Given this list of marker genes C1QL1, CAPS, DAO, MAPK1, SPATA2L, LRMDA, GABBR1, C3AR1, B4GALT1, CTAGE9, CDKN1C, AZGP1, EPHB6, PLXNA1, PLAUR, GNAQ, DDIT3, EPHB4, RAB11B, LMNA, SLC6A8, PI16, MGC16275, KCNH2, GSTA4, MIR3147HG, NPPA, POFUT2, GGTA1, PDGFB, HMCES, PTBP3, TRIOBP, RHPN1, PRX, SPAG8, POU2F2, SASH1, HYI, PHF1, HS3ST2, RAB11FIP1, DSP, HRK, NAP1L1 (NCBI Gene Id 64165), AKR1C1, BIRC7, CEP170B, MBP (NCBI Gene Id 4155), ODAD3, MYZAP, MAPK8IP2, STYK1, RPL37A, NOXA1, DMTN, GIT1, NTRK3, NPEPL1, PPFIA3, KHSRP, MOB3A, CEBPA-DT, MIR9-1HG, CXCL1 (C-X-C motif chemokine ligand 1), USP27X-DT, PIK3CD, HMGA1P4, AKAP7, DDR1, TUBB2B, CTRB2, LINC02574, MAMLD1, PYGL, MIR23AHG, MITF, FMOD, PICK1, MAP2K3, SNTA1, PINK1, MRC2, GNA11, SNN, AMN, COL11A2, here is a description of the gene set: B-cell activating factor (BAFF) and a proliferation-inducing ligand (APRIL) have been shown to promote multiple myeloma (MM) cell growth. We show that the main site of production for BAFF and APRIL is the bone marrow (BM) environment, and that production is mainly by monocytes and neutrophils. In addition, osteoclasts produce very high levels of APRIL, unlike BM stromal cells. Myeloma cells (MMCs) express TACI (transmembrane activator and calcium modulator and cyclophilin ligand interactor), the receptor of BAFF/APRIL, at varying levels. TACI expression is a good indicator of a BAFF-binding receptor. Expression data of purified MMCs from 65 newly diagnosed patients have been generated using Affymetrix microarrays and were analyzed by supervised clustering of groups with higher (TACI(hi)) versus lower (TACI(lo)) TACI expression levels. Patients in the TACI(lo) group had clinical parameters associated with bad prognosis. A set of genes was differentially expressed between TACI(hi) and TACI(lo) MMCs. This set makes it possible to efficiently classify TACI(hi) and TACI(lo) MMCs in an independent cohort of 40 patients. TACI(hi) MMCs displayed a mature plasma cell gene signature, indicating dependence on the BM environment. In contrast, the TACI(lo) group had a gene signature of plasmablasts, suggesting an attenuated dependence on the BM environment. Taken together, our findings suggest using gene expression profiling to identify the group of patients who might benefit most from treatment with BAFF/APRIL inhibitors. Genes up-regulated in normal bone marrow plasma cells (BMPC) compared to polyclonal plasmablasts (PPC) that also distinguished multiple myeloma (MM) samples by expression of levels of TACI (TNFRSF13B). studied in species Homo sapiens from publication Moreaux J, Cremer FW, Reme T, Raab M, Mahtouk K, Kaukel P, Pantesco V, De Vos J, Jourdan E, Jauch A, Legouffe E, Moos M, Fiol G, Goldschmidt H, Rossi JF, Hose D, Klein B (PMID 15827134) Human Gene Set: MOREAUX_B_LYMPHOCYTE_MATURATION_BY_TACI_UP